Given this list of marker genes SLC26A2, SLC35B2, TRPV4, ARSL, FLNB, POGZ, SOX9, EBP, here is a description of the gene set: Human Gene Set: HP_APLASIA_HYPOPLASIA_OF_THE_CERVICAL_SPINE Aplasia or developmental hypoplasia of the cervical vertebral column. Aplasia/Hypoplasia of the cervical spine studied in species Homo sapiens